The following is a description of a gene set: Human Gene Set: HP_APLASIA_HYPOPLASIA_OF_THE_PUBIC_BONE species: Homo sapiens Aplasia/Hypoplasia of the pubic bone Absence or underdevelopment of the pubic bone., and this is the list of marker genes: SETBP1, KAT6B, CTBP1, COL11A2, CPLX1, ABCC9, FGFR2, OBSL1, TBX15, COL2A1, CCDC8, PIGG, INPPL1, HSPG2, LETM1, NELFA, MATN3, NSD2, CUL7, WNT7A, INTU